Given this list of marker genes Ccnd1 (cyclin D1), Sox9, Ppm1d, Psmc5, Skp1, Ubc, Psmd1, Rbx1, Psmb2, Psmd13, Psmc4, Psmb3, Rbm14, Runx2, Psmc1, Uba52, Adrm1, Stub1, Cbfb, Uba52rt (ubiquitin A-52 residue ribosomal protein fusion product 1, retrotransposed), Cul1, Psma4, Ar, Rps27a, Skp2, Psmc6, Smad4, Psmd11, Ubb, Psmb6, Psma7, Psmb5, Smad1, Ccnb1, Psmd14, Cdk1, Psmd2, Psma1, Psma2, Psmd3, Psmb7, Cdk4, Psmb1, Psma6, Psmd8 (proteasome (prosome, macropain) 26S subunit, non-ATPase, 8), Psmc2, Psma3, Psmc3, Psmd7, Psmd12, Psmd6, Psma5, Psmb4, here is a description of the gene set: species: Mus musculus Mouse Gene Set: REACTOME_TRANSCRIPTIONAL_REGULATION_BY_RUNX2 Transcriptional regulation by RUNX2